Given this list of marker genes MSI2, ASPSCR1, RNF213, BCL6, HLF, PRKAR1A, here is a description of the gene set: from publication Myllykangas S, Himberg J, Böhling T, Nagy B, Hollmén J, Knuutila S (PMID 16751803) Human Gene Set: MYLLYKANGAS_AMPLIFICATION_HOT_SPOT_5 species: Homo sapiens DNA copy number amplifications activate oncogenes and are hallmarks of nearly all advanced tumors. Amplified genes represent attractive targets for therapy, diagnostics and prognostics. To investigate DNA amplifications in different neoplasms, we performed a bibliomics survey using 838 published chromosomal comparative genomic hybridization studies and collected amplification data at chromosome band resolution from more than 4500 cases. Amplification profiles were determined for 73 distinct neoplasms. Neoplasms were clustered according to the amplification profiles, and frequently amplified chromosomal loci (amplification hot spots) were identified using computational modeling. To investigate the site specificity and mechanisms of gene amplifications, colocalization of amplification hot spots, cancer genes, fragile sites, virus integration sites and gene size cohorts were tested in a statistical framework. Amplification-based clustering demonstrated that cancers with similar etiology, cell-of-origin or topographical location have a tendency to obtain convergent amplification profiles. The identified amplification hot spots were colocalized with the known fragile sites, cancer genes and virus integration sites, but global statistical significance could not be ascertained. Large genes were significantly overrepresented on the fragile sites and the reported amplification hot spots. These findings indicate that amplifications are selected in the cancer tissue environment according to the qualitative traits and localization of cancer genes. Amplification hot spot 5: colocolized fragile sites and cancer genes in the 17q22-q25 region.